Given this list of marker genes Pik3r4, Fig4, Mtmr2, Pik3c2a, Mtmr4, Pik3c3, Vac14, Mtmr7, Mtm1, Pikfyve, here is a description of the gene set: Mouse Gene Set: REACTOME_SYNTHESIS_OF_PIPS_AT_THE_LATE_ENDOSOME_MEMBRANE species: Mus musculus Synthesis of PIPs at the late endosome membrane